The following is a description of a gene set: species: Homo sapiens Glucocorticoids play a role in regulation of T lymphocytes homeostasis and development. In particular, glucocorticoid treatment induces massive apoptosis of CD4+CD8+ double positive (DP) thymocytes. This effect is due to many mechanisms, mainly driven by modulation of gene transcription. To find out which genes are modulated, we analyzed DP thymocytes treated for 3 hours with dexamethasone or medium alone, by global gene expression profiling using the Affymetrix technology (MGU74Av2 GeneChip). The data were analyzed with MAS 5.0 imposing a cut off of 1.7 fold in up regulation and 1.35 fold in down regulation. To further filter results we also used the statistical software, SAM (d 0.88 see figure 1s in supplementary data of the above cited manuscript). Results indicate modulation of genes, also confirmed by either RNAse protection assay or Real Time PCR. For data mining we also used Go Miner to explore the Gene Ontology data bank (see tables 1-3 of the above cited manuscript). The overall results demonstrated that dexamethasone caused the down-regulation of genes promoting survival of DP thymocytes (e.g. Notch1, Socs1 and Id3) or the modulation of genes activating cell death through the ceramide pathway (Ugcg, Sgpp1, Degs1 and Gpr65) or through the mithocondrial machinery. Among the latter, there are Bcl-2 family members (Bim, Bfl-1, Bcl-xL and Bcl-xbeta), genes involved in the control of redox status (thioredoxin reductase, TXNIP and idh2) and genes belonging to Tis11 family which are involved in mRNA stability. Our study suggests that dexamethasone treatment of DP thymocytes modulates several genes belonging to apoptosis-related systems that can contribute to their apoptosis. from publication Bianchini R, Nocentini G, Krausz LT, Fettucciari K, Coaccioli S, Ronchetti S, Riccardi C (PMID 16914556) Human Gene Set: GSE5463_CTRL_VS_DEXAMETHASONE_TREATED_THYMOCYTE_UP Genes up-regulated in comparison of control thymocytes versus thymocytes treated with dexamethasone., and this is the list of marker genes: MAP3K1, KLF10, LCP2, MYOZ1, PHB2, KIAA1191, CMTM6, IFNAR2, FKBP1A, CS, POLE4, CIC, C16orf74, CD74, MAPK7, PLEKHO1, H2AB2, VPS72, TDRP, LONP2, GRB7, LTBR, ARID3B, MAP1LC3A, NUDT3, SEPTIN9, RCC2, IL4R, CAMSAP1, BIN1, TCF20, CTSW, TOP2B, CBX4, SOCS1, MPV17, SIAH1, REX1BD, SLC35C2, CDK4, JKAMP, BHLHE40, EIF3G, VAV2, PDCD7, SELPLG, HMGCS1 (NCBI Gene Id 3157), CRY1, DPAGT1, LATS2 (large tumor suppressor kinase 2), CIAO2B, GDI1, HLA-DQA1, RNF5, TRAK1, SLC20A1, TNPO2, CYTH2, CDKN2C, ERBB3, ZFPM1, ALDH3A1, PPTC7, ALCAM, TBC1D1, KCNMB1 (NCBI Gene Id 3779), MPRIP, MAP4K1, PNKP (polynucleotide kinase 3'-phosphatase), SLC25A11 (NCBI Gene Id 8402), TPRG1L, YWHAH, TAF8, TNFRSF1B, COX17, DNAAF5, HDAC7, MLX, TRAPPC2L, MAP2K6, LPIN1, ABCD1, ARHGDIA, BYSL (NCBI Gene Id 705), GTSE1, NDUFB10, NELFE, LTB, HIBADH, EIF1, TNIP1, RPL22, NDEL1, SMAD4 (SMAD family member 4), TGDS, TP53, NEK2, S100A11, DBP, KLF3, ADCY6, GRK2, BOLA3, GPSM3, NFKBIB, MBD1, ST3GAL4, SOX17, CDR2, TRAPPC5, RGCC, VTA1, AHNAK, CACNA2D1, TIMM10, CISD1 (CDGSH iron sulfur domain 1), TRIR, SIRPA, CMAS, NR2F6, LCP1, SOX4, CD37, TAP1, COPE, MAFF, BCL10, FNBP1, PIM3, C1orf52, IL2RA, IGF2R, F2RL3, UBE4B, DUSP12, UGCG, STAT1, IRF6, B3GNT2, UNC45A, LGALS1, CYTH1, STK3, LRRC58, SMS, IL27RA, LSM3, TAGLN2, PSTPIP1, CD27 (CD27 molecule), CD52, GPCPD1, WDR48, CD1D, SLC4A2, STX2, SMTN, IRS2, VPS37B, SLC35B1, TMEM230, PKNOX1, OSBPL5, P2RX1, CSNK1E, KIAA2013, DIPK2A, TGM3, ASB6, HDHD2, PSMD13, RBM4B, GABARAPL2, TLK2, CRELD2, MSMO1, MGST3, LASP1, PDZD11, FAM53A, CXXC5, PAFAH1B2, CMTM7, NTN1, AP1B1 (NCBI Gene Id 162), CLIC4, FARSB, SEMA7A, EIF4A2, AZIN1, SEPSECS, BRI3, UBXN8, AGPAT5, RGL2, LAMB3 (laminin subunit beta 3), GALNT2, COL12A1, RDH11, TGFB1